Given this list of marker genes ATP10A, FAM199X, H1-7, MBD2, CYP1A1, SNTB1, TRIM34 (NCBI Gene Id 53840), PLCB1, RAB10, ART2P, YWHAG, DTNA, here is a description of the gene set: Genes down-regulated in small intestine upon loss of both APC and MBD2. studied in species Mus musculus from publication Phesse TJ, Parry L, Reed KR, Ewan KB, Dale TC, Sansom OJ, Clarke AR (PMID 18644872) We have previously shown that deficiency of the methyl binding domain protein Mbd2 dramatically reduces adenoma burden on an Apc(Min/+) background. To investigate the mechanism underlying this phenomenon, we have determined the effect of Mbd2 deficiency upon the phenotypes imposed by the conditional deletion of Apc in the small intestine. Microarray analysis demonstrated a partial suppression of the Wnt pathway in the absence of Mbd2. Mbd2 deficiency also influenced one immediate cellular consequence of Apc loss, with normalization of Paneth cell positioning. From a mechanistic perspective, we show that deficiency of Mbd2 elevates levels of the known Wnt target Lect2, and we confirm here that Mbd2 binds the Lect2 promoter in association with NuRD. Furthermore, we show that Lect2 is capable of functioning as a Wnt pathway repressor. These results therefore provide a mechanistic basis for the epigenetic control of adenoma formation mediated through Mbd2. Human Gene Set: PHESSE_TARGETS_OF_APC_AND_MBD2_DN